The following is a description of a gene set: part of: Mucopolysaccharidoses studied in species Homo sapiens Mucopolysaccharidosis IX (MPS IX, Natowicz syndrome, Hyaluronidase deficiency, MIM:601492) is a rare lysosomal storage disease characterized by high hyaluronan (HA) concentration in the serum resulting from deficiency in hyaluronidase 1 (HYAL1, MIM:607071) which normally hydrolyses 1-4 linkages between N-acetylglucosamine (GlcNAc) and D-glucuronate (GlcA) residues. Symptoms of MPS IX are periodically painful soft tissue masses around the joints, acquired short stature and erosion of the hip joint, although joint movement and intelligence are normal. Reactome Pathway: MPS IX - Natowicz syndrome (CS/DS degradation), and this is the list of marker genes: HYAL1